The following is a description of a gene set: studied in species Homo sapiens A deviation from normal signal on magnetic resonance imaging (MRI) of the brainstem. Abnormal brainstem MRI signal intensity Human Gene Set: HP_ABNORMAL_BRAINSTEM_MRI_SIGNAL_INTENSITY, and this is the list of marker genes: AIFM1, PDCD10, NDUFA1, NDUFA11, NDUFA6, PIK3CA, NDUFS2, CCM2, FOXRED1 (FAD dependent oxidoreductase domain containing 1), NDUFB11, NDUFV2, NDUFS7, NDUFAF5 (NADH:ubiquinone oxidoreductase complex assembly factor 5), MT-ND3, GTPBP3, KRIT1, NDUFS4, TIMMDC1, NDUFB10, NUBPL, NDUFAF2, SLC19A3, MTRFR, MT-ND1, LAMA2, RANBP2, ATP7B, TMEM126B, NDUFS1, NDUFAF3, NDUFAF8, ETHE1, NDUFV1, NDUFAF1, NDUFB3, NDUFS8, MT-ND2, NDUFAF4, SCO2, NDUFS3, NDUFS6, NDUFB9